Given this list of marker genes Cul1, Ubb, Ikbkb, Nfkb1, Rps27a, Map3k8, here is a description of the gene set: This event has been computationally inferred from an event that has been demonstrated in another species.<p>The inference is based on the homology mapping from PANTHER. Briefly, reactions for which all involved PhysicalEntities (in input, output and catalyst) have a mapped orthologue/paralogue (for complexes at least 75% of components must have a mapping) are inferred to the other species. studied in species Mus musculus part of: Interleukin-1 signaling; MAP kinase activation Reactome Pathway: MAP3K8 (TPL2)-dependent MAPK1/3 activation electronically inferred by orthology from the curated human pathway